The following is a description of a gene set: A ubiquitin ligase complex in which a cullin from the Cul3 subfamily and a RING domain protein form the catalytic core; substrate specificity is conferred by a BTB-domain-containing protein. species: Mus musculus Mouse Gene Set: GOCC_CUL3_RING_UBIQUITIN_LIGASE_COMPLEX, and this is the list of marker genes: Kctd17 (NCBI Gene Id 97993), Depdc5, Gan, Kbtbd2, Klhl15, Pef1, Klhl20, Klhl17, Klhl6, Keap1, Klhl9, Klhl29, Glmn, Spop, Cul3, Klhl2, Klhl3, Klhl24, Klhl25, Klhl8, Kbtbd8, Pdcd6, Arih1, Klhl13, Klhl7, Klhl11, Klhl40, Klhl42, Spopl, Zswim8, Klhl30, Katna1, Klhl35, Klhl21, Klhl22, Klhl23, Klhl1, Rbx1, Enc1, Klhl4, Kctd2, Klhl18, Lztr1, Ccin, Kbtbd12, Ipp, Klhl12, Kctd13, Klhl5, Rbx1-ps, Klhl41, Kctd10, Kbtbd6, Tnfaip1, Klhl28, Kbtbd7, Klhl10, Ivns1abp (NCBI Gene Id 98245), Klhl38, Kbtbd3, Kctd5